Given this list of marker genes GABRG2 (NCBI Gene Id 2566), SLC6A1, SCN1A, IQSEC2, SYNGAP1 (NCBI Gene Id 8831), AP2M1, SLC2A1, NEXMIF, CHD2, FRRS1L, SATB1, GRIN2A, TBC1D24 (NCBI Gene Id 57465), SRPX2, DAG1, CPLX1, here is a description of the gene set: EEG with focal spike waves species: Homo sapiens Human Gene Set: HP_EEG_WITH_FOCAL_SPIKE_WAVES EEG with focal sharp transient waves of a duration less than 80 msec followed by a slow wave.